The following is a description of a gene set: Human Gene Set: GOBP_REGULATION_OF_SIGNAL_TRANSDUCTION_BY_P53_CLASS_MEDIATOR Any process that modulates the frequency, rate or extent of signal transduction by p53 class mediator. species: Homo sapiens, and this is the list of marker genes: MLXIPL, DYRK3, TAF1, STK11, PSMD10, HAPSTR1, EP300, NPM1, ARMC10, HEXIM1, ING2, PMAIP1, SGK1, BCL2L12, DYRK2, TWIST1, AURKB, SMARCA4, USP2, AURKA, HNRNPK, PTTG1IP, CD44, ATAD5, RPL5, PAK1IP1, RPS15, ZNF385A, PLK3, DYRK1A, BCL2, MIF, SPRED2, RPF2, MARCHF7, MYC, SOX4, ZNHIT1, RFFL, MSX1, TP53BP1, PPP1R15A, PML, NOP2, MIR186, TRIM24, MORN3, ZMPSTE24, NOP53, MTOR, RPL26, RPL37, PLA2R1, SETD9, SNAI1, MDM2, KDM1A, HIC1, DVL2, EIF5A, AKT1, ATM, BDKRB2, EEF1E1, CHEK2 (NCBI Gene Id 11200), CDK5RAP3, HIPK2, RPS7, RRM2B, YJU2, TP53RK, RPL23, ANKRD1, TP73, AARS1, URB2, ELL3, RPL11, PIP4P1, KDM8, RNF34, MAPKAPK5, PRMT6, TRIAP1, CHEK1 (NCBI Gene Id 1111), CDKN2A, MIR21, CD74, PRKN, MUC1, TIFAB, PYHIN1, ING4, TAF9, UBB (NCBI Gene Id 91253), TAF9B, RRN3, MLF1, SIRT1, USP7, TP53, CSNK2A1, CHD5, RRS1, RPS20, HIPK4, SNAI2, ATR, MAP2K6, COPS3, USP15, TAF3, DDX5, SMYD2, KMT5A, NUAK1, SPRED1, KAT6A, BOP1 (NCBI Gene Id 727967), PRMT5